The following is a description of a gene set: Reactome Pathway: Translesion synthesis by REV1 part of: Translesion synthesis by Y family DNA polymerases bypasses lesions on DNA template species: Homo sapiens REV1 (hREV1) encodes a template-dependent dCMP transferase that can insert a C residue opposite an abasic site. Interaction with monoubiquitinated PCNA at a DNA damage site enhances REV1-mediated translesion synthesis (TLS). After REV1 incorporates dCMP opposite to the apurinic/apyrimidinic (AP) template site, TLS is continued by the DNA polymerase zeta complex (POLZ). POLZ consists of the catalytic subunit REV3L and the accessory subunit MAD2L2 (REV7). MAD2L2 binds REV1, thus recruiting POLZ to DNA damage site. POLZ is error-prone and contributes to TLS-related mutagenesis. POLZ has a low processivity and dissociates from the DNA template after incorporating less than 30 nucleotides., and this is the list of marker genes: RPA2, UBC, RPS27A, REV3L, RPA3, RFC4 (NCBI Gene Id 5984), REV1, PCNA, RFC3, RPA1, RFC1, UBA52, RFC5, UBB, MAD2L2, RFC2